The following is a description of a gene set: Cytokines mediate cell-cell communication in the immune system and represent important therapeutic targets. A myriad of studies have highlighted their central role in immune function, yet we lack a global view of the cellular responses of each immune cell type to each cytokine. To address this gap, the authors created the Immune Dictionary, a compendium of single-cell transcriptomic profiles of more than 17 immune cell types in response to each of 86 cytokines (>1,400 cytokine-cell type combinations) in mouse lymph nodes in vivo. A cytokine-centric view of the dictionary revealed that most cytokines induce highly cell-type-specific responses. For example, the inflammatory cytokine interleukin-1β induces distinct gene programmes in almost every cell type. A cell-type-centric view of the dictionary identified more than 66 cytokine-driven cellular polarization states across immune cell types, including previously uncharacterized states such as an interleukin-18-induced polyfunctional natural killer cell state. from publication Cui A, Huang T, Li S, Ma A, Pérez JL, Sander C, Keskin DB, Wu CJ, Fraenkel E, Hacohen N (PMID 38057668) studied in species Mus musculus Mouse Gene Set: CUI_MACROPHAGE_IL13_RESPONSE_UP Genes positively differentially expressed in cell type: Macrophage upon treatment with cytokine: IL-13 in mouse lymph nodes in vivo., and this is the list of marker genes: Ccl9, Ccl8, Serpina3f, Nop56, Eif4a1, Ran, Srm, Snx2 (sorting nexin 2), Chchd10, Ncl, Glrx, Cdk4, Sdc4 (NCBI Gene Id 99320), Set, Lpl, Cacybp, Fcgr2b, Hmox1, Pdcd1lg2, Ccl6, Cycs (NCBI Gene Id 13063), Ak2, Cd209e, Irf7, Eif5a, Ctu2, Ccl12, Nhp2, Serpina3g, Hspd1